The following is a description of a gene set: Human Gene Set: GSE33424_CD161_INT_VS_NEG_CD8_TCELL_UP from publication Walker LJ, Kang YH, Smith MO, Tharmalingham H, Ramamurthy N, Fleming VM, Sahgal N, Leslie A, Oo Y, Geremia A, Scriba TJ, Hanekom WA, Lauer GM, Lantz O, Adams DH, Powrie F, Barnes E, Klenerman P (PMID 22086415) We used microarray to compare gene expression between CD161++/CD161+/CD161-CD8+ T cells from human cord blood. Genes up-regulated in CD8 T cells: KLRB1 int versus KLRB1-. studied in species Homo sapiens, and this is the list of marker genes: CD69, MRPL1, NCOA7 (nuclear receptor coactivator 7), EHD3, YARS1, USP18, HSH2D, CSDE1, UTP20, TMEM140, EVI2A, CGAS, COX18, RBL1, C19orf12, ZCCHC2, NUTF2, RNF213, HAP1, SLFN12L, PPM1K, SGCB, N4BP1, LARP1, TNFSF10 (TNF superfamily member 10), CD86, TPST1, ELF1, MTHFD1, PUM3, DAXX, PNPT1, LPAR6, ISG15, CASP4, UBE3D (ubiquitin protein ligase E3D), WDR75, CD47 (CD47 molecule), ABCB1, TDRD7, PARP9, PLAC8, SFXN2, SERPINI1, GBP7, DPP4, C7orf50, RNASEL, OAS2, CXCL10, OASL, NUFIP1, ZEB2, PARP11, PSMD11, DNAJC13, RPS2, IL12RB1, POLR3B, ELL3, RTP4 (NCBI Gene Id 64108), SMYD2 (SET and MYND domain containing 2), CHIC1, MED12L, MCOLN3, IRGM, ZNF365, PABPC1, DNAJC2, DTX3L, TOR3A, GPR171, CIPC, ST13, HMGN3, OAS3, TMA16, PMEPA1, RIGI, CMPK2, SLC25A12, IFI44L, ZCCHC18, TRIM21, IFIT2, DCAF1, MPEG1, TOR1AIP2, SNHG32, LAP3, HSPA5, CD300LF, MITD1, IFIT3, ASNS, PNO1, STAT1, NT5C3A, HERC6, CCT5, GYPC, GBP6, PRMT5, GPR65, CCND2, CCNL1, CHD7 (chromodomain helicase DNA binding protein 7), OAS1, TOMM70, GBP2, TRIM5, SLFN5, BBX, MX2, CSF1, SMARCAL1, CFAP210, ISG20, CYBB (NCBI Gene Id 1536), MDN1, LIPT1, PGD, DDX60, PML, RILPL1, PARP14, MX1, ASB13, TRAFD1, PKIB, PFKFB3, LY86, GART, CARMIL1, LGALS3BP, TLR3, INPP1, AGRN, ZBP1, NIT2, EPSTI1, ZFP1, SAMD9L, STAT2, ANGPTL1, HLA-E, IRF1, IFIT1, IFITM3, CHRAC1, SETDB2, NOP58, TLR7, PDE7B, MGST2, MPHOSPH10, HCK, DLL1, TENT4A, SCAMP2, DHX58, IRF9, NIFK, CD274, MARCHF5, EIF2AK2, UBXN2B, NLRC5, PPA1, IRF7, PELI1, UBALD2, IFIT1B, IFI35, ST3GAL6, GNL3, XAF1, SAMHD1, ETV6, SIDT1, NMRAL1, SLFN13, TAPBP, PARP12, CNR2, RSAD2, IFI44, ZUP1, TGIF1, CCRL2, LPXN, TMEM185A, BAZ1A, CALHM6, N6AMT1, NMI, NAMPT, IFIH1, RASGEF1B, AK7